The following is a description of a gene set: Mouse Gene Set: GOMF_UDP_GLYCOSYLTRANSFERASE_ACTIVITY Catalysis of the transfer of a glycosyl group from a UDP-sugar to a small hydrophobic molecule. studied in species Mus musculus, and this is the list of marker genes: Colgalt1, B4galnt1, Galnt9, Galntl6, Ugt2a2, Poglut3, Ugt2b5, B3gnt6, Mgat5b (NCBI Gene Id 268510), Ugt2b36, Poglut1, Pomgnt1, Ugt2b1, Mgat4d, Gxylt2, Mgat2, Mgat4e, Csgalnact2, B4galnt3, Galnt12, Chpf2, Xylt2, Glt8d2, Galnt11 (NCBI Gene Id 320282), B3gnt9, Gcnt3, Lalba, Gyg1, B4galt3, B3galt6, Extl2, Uggt2, Poglut2, Gcnt1, B4galt4, B4galt6, 4930568D16Rik (NCBI Gene Id 75859), Colgalt2, Ugt1a8, B4galt5, Rxylt1, B3gntl1, Cercam, B3gnt4, Gys2, Ugt2a3, B3gnt8, Ugt2b35, B3gat2, Alg5, Has1, Mgat3, Epm2a, Ogt, B3gat3, Gxylt1, Mgat5, Ugcg, B3galnt2 (NCBI Gene Id 97884), B3gnt3, Ext1, Extl3, Pomgnt2, B4galt7, Galnt18, B3galt4, Galnt4, Glt8d1, B3galt5, Large1, Ugt2b34, B4galt1 (NCBI Gene Id 99960), Pigq, Galnt16, Ugt8a, Lfng, Pigyl, Galnt5 (polypeptide N-acetylgalactosaminyltransferase 5), Chsy1, Ugt1a6a, B4galt2, Hexa, Mfng (NCBI Gene Id 17305), Ugt1a6b (UDP glucuronosyltransferase 1 family, polypeptide A6B), Gys1, B4gat1, Ugt1a10, Pigp, Mgat1, A3galt2, B4galnt4, Ugt2a1, Piga, Eogt, A4galt (NCBI Gene Id 432970), Hexb, B3galnt1, B3galt2, Galnt7, Csgalnact1, Chsy3, Has3, Gcnt2, Hyal1, Plod3, Alg13, Galnt14, Extl1, Galnt15, Gcnt7, Galnt1, A4gnt, Gbgt1, Has2, Xxylt1, B3gnt2, Galnt2, Galnt6, Ugt1a7c, Mgat4c, Ugt1a1, B3glct, Wdfy3, Mgat4b, Abo, Galnt17, Ugt2b38, Rfng, Gcnt4, B3gnt5, Ugt1a2 (NCBI Gene Id 270363), B4galnt2, B3galt1, Galnt10, Mgat4f, B3gat1, Large2, Ggta1, Galnt13, B3gnt7, Mgat4a, Ugt2b37, Uggt1, Xylt1, Ugt1a9, Galnt3, Ugt3a1, Ugt1a5, Ugt3a2, Ext2, Chpf